The following is a description of a gene set: studied in species Homo sapiens from publication Schaefer CF, Anthony K, Krupa S, Buchoff J, Day M, Hannay T, Buetow KH (PMID 18832364) Human Gene Set: PID_RAC1_REG_PATHWAY Regulation of RAC1 activity, and this is the list of marker genes: MCF2, DOCK2, ELMO1, CHN2, SOS1, BCR, ARHGEF25, ARHGEF7 (Rho guanine nucleotide exchange factor 7), DEF6, KALRN, RACGAP1, ARHGAP9, RAP1GDS1, ARHGEF6, ABR, RASGRF1, SPATA13, DOCK1, NGEF, PREX2, ARHGEF2, RAC1, TIAM1, RALBP1, VAV3 (vav guanine nucleotide exchange factor 3), ARHGAP17, RASGRF2, ARHGAP1, DOCK6, TIAM2 (TIAM Rac1 associated GEF 2), CHN1, TRIO, ARHGDIA, VAV2, EPS8, ABI1, PREX1, VAV1